Given this list of marker genes ATXN3, ADH1C, SNCA, MT-TT, GBA1, VPS13A, SLC20A2, FTL, SNCAIP, MAPT, PDGFRB, TBP, ATXN8OS, NR4A2 (nuclear receptor subfamily 4 group A member 2), PDGFB, ATXN2, here is a description of the gene set: species: Homo sapiens Human Gene Set: HP_MICROGRAPHIA Micrographia Abnormally small-sized handwriting is formally defined as an impairment of fine motor skills, which mainly manifests as a progressive or stable reduction in amplitude during a writing task.